Given this list of marker genes CER1, CRIPTO, NOMO3, BMPR2, SMURF1, FOXH1, FSTL3, GDF7, BMP10, FGF10 (fibroblast growth factor 10), DAND5, SMAD3, TGFBR1, CFC1, DACT2, CSNK2B, SMAD4, CFC1B, SMAD7, SKI (NCBI Gene Id 6497), CITED2, DACT1, LEMD3, FGF9, FKBP1C, ACVR1B, SMAD6, NOMO1, NCLN, TGIF1, IGSF1, FST, CRIPTO3, INHBB, FKBP1A, GDF11, TGFBR2, ACVR2B, TGIF2, NODAL, ACVRL1, ACVR1C, SMAD2, GDF6, INHBA, ACVR2A, DMRT1, HJV, NOG, GDF2, ZC3H3, SHH, MAGI2, ACVR1, here is a description of the gene set: The series of molecular signals initiated by an extracellular ligand binding to an activin receptor on the surface of a target cell, and ending with the regulation of a downstream cellular process, e.g. transcription. Human Gene Set: GOBP_ACTIVIN_RECEPTOR_SIGNALING_PATHWAY studied in species Homo sapiens